The following is a description of a gene set: Human Gene Set: GOBP_GPI_ANCHOR_METABOLIC_PROCESS species: Homo sapiens The chemical reactions and pathways involving glycosylphosphatidylinositol anchors, molecular mechanisms for attaching membrane proteins to the lipid bilayer of cell membranes. Structurally they consist of a molecule of phosphatidylinositol to which is linked, via the C-6 hydroxyl of the inositol, a carbohydrate chain. This chain is in turn linked to the protein through an ethanolamine phosphate group, the amino group of which is in amide linkage with the C-terminal carboxyl of the protein chain, the phosphate group being esterified to the C-6 hydroxyl of the terminal mannose of the core carbohydrate chain., and this is the list of marker genes: PIGS, DPM1, GPAA1, SLC30A5 (NCBI Gene Id 79021), PIGA, PIGZ, PIGC, PGAP1, PIGX, PIGQ, PIGO, PIGV, PIGU, PGAP3, PIGY, DPM3, PIGT, PIGB, PIGP, PIGG, PIGF, PIGK, MPPE1 (metallophosphoesterase 1), PGAP4, PIGH, PIGL, DPM2, CWH43, PIGN, PIGM, PIGW, PGAP2